The following is a description of a gene set: Nitric oxide (NO) produced by macrophages (MØs) is toxic to both host tissues and invading pathogens and its regulation is therefore essential to suppress host cytotoxicity. MØ arginase 1 (Arg1) inhibits NO production by competing with NO synthases for arginine, the common substrate of NO synthases and arginases. Two signal transduction pathways control Arg1 expression in MØs. First, a MyD88-dependent pathway induces Arg1 in intracellular infections, while a second Stat6-dependent pathway is required for Arg1 expression in alternativelyactivated MØs. We found that mycobacteria-infected MØs produce soluble factors that induce Arg1 in an autocrine-paracrine manner via Stat3. We identify these factors as IL-6, IL-10 and GCSF. We further establish that Arg1 expression is controlled by the MyD88-dependent production of IL-6, IL-10 and G-CSF rather than cell intrinsic MyD88 signaling to Arg1. Our data reveal the MyD88-dependent pathway of Arg1induction following BCG infection requires Stat3 activation and may result in the development of an immunosuppressive niche in granulomas due to the induced Arg1 production in surrounding uninfected MØs Human Gene Set: GSE22935_UNSTIM_VS_24H_MBOVIS_BCG_STIM_MYD88_KO_MACROPHAGE_UP Genes up-regulated macrophages with MYD88 knockout: untreated versus 24h after M. bovis BCG infection. studied in species Homo sapiens from publication Qualls JE, Neale G, Smith AM, Koo MS, DeFreitas AA, Zhang H, Kaplan G, Watowich SS, Murray PJ (PMID 20716764), and this is the list of marker genes: NR4A1, RAB1A, IL6ST, USP22, PUS3, FBXL3, TTPAL, AGO2, RELL1, PLA2G6, FGFBP3, ERCC1, COX17, LPXN, LRP8, GNPDA2, MAPKAPK5, KRAS, SPECC1L, PPP4R1, PXDC1, HSPA13, FTH1, ARPC5 (actin related protein 2/3 complex subunit 5), CCSER2, DUSP3, IFRD1, CDC42SE1, FURIN, TLK2, CYP11A1, TBPL1, PNPLA8, GMEB1, ELL2, IL1R2, CD300LB, MAP1LC3B, SAP30L, ABCC1, STAM, PEDS1, JADE2, NHSL3, SLC7A5, MAP2K3, LAT, UHRF2, ARF4, SLAIN2, RHBDL3 (NCBI Gene Id 162494), HMOX1, MAFK, ATP2B1, TAF7, RNF11, ZNF438, DNTTIP1, UBE2B, BTAF1, INTS13, CAMK1D, RYBP, GGA2, PRR13, MEIS1, BTG3, TSG101, EDEM1 (NCBI Gene Id 9695), RNF24, MIDN, TAB3, UBOX5, PLEK, KPNA4, ROCK2, RAB20, TUSC1, NFIL3, BLVRB, RAB18, BIRC3, SLC9A5, JUND, IL18RAP, SYS1 (SYS1 golgi trafficking protein), MLXIP, SWAP70, DUSP1, B3GNT5, FOXN3, ABHD2, WBP2 (NCBI Gene Id 96240), CYTH3, CDK17 (cyclin dependent kinase 17), FAM98A, CKAP4, DAPP1, PAFAH1B1, TMEM43, CXCL10, QSER1, CD83, GUCD1, PDCD10, DSTYK, MARCHF5, ITPRIPL2, DPM2, BDP1, PRDM4, CRTC2, TANC2, RWDD4, PCGF5, C14orf28, SOCS7, DBNDD1, GFPT1, CAST, PDCD1LG2, SLC49A4 (solute carrier family 49 member 4), C3orf38, CASP4, GPAT3, UBE2J2, MEX3C, PDGFB, PIP4K2C, ZBTB18, RFXAP, ZNF655, HAX1, RELB, SLC1A4, ASF1A, BCL10, RAB43, GFOD1, ATXN1L, GTF2F1, NEU1 (neuraminidase 1), FCRL1, NKIRAS2, USP31, CHMP2A (charged multivesicular body protein 2A), XPOT, PPP1R13B, SIDT2, AKAP6, GABPA, AZI2, VWF, ANXA3, DNAJC21, SLC41A2, CSRNP1, BIRC2, MICALL1, SOCS6, NABP1, TNIP1, LEMD2, SOWAHC, NFE2L2, ITGA9, GNAQ, POGK, RBMS1, ZEB1, B4GALT1, RHOQ, DVL1, EOMES, AIFM2 (NCBI Gene Id 84883), SPRED2, AMMECR1L, PIGC, CAMLG, PIK3C2A, MPZL3, CWC25, CNOT4, YPEL5, PON2, ATP6V0C, FAM53C, HILPDA, P2RX4, EPHA2, TAX1BP1, ZBTB21, ANKIB1, HS6ST1, PAIP2, CRISP3, TRIP10, ATF5, PTGR1, OPLAH